The following is a description of a gene set: studied in species Mus musculus Any process that modulates the frequency, rate or extent of AMPA selective glutamate receptor activity. Mouse Gene Set: GOBP_REGULATION_OF_AMPA_RECEPTOR_ACTIVITY, and this is the list of marker genes: Prrt1, Reln, Nlgn1, Cnih2, Shisa7, Cnih3 (NCBI Gene Id 72978), Nlgn2, Shank1, Cacng8 (calcium channel, voltage-dependent, gamma subunit 8), Shisa9, Cacng2, Nlgn3, Gsg1l, Cacng7, Cacng5, Cacng4, Adrb2, Mink1, Cacng3, Mapk8ip2